Given this list of marker genes ANO5, UNC45B, SNUPN, ACTN2, KY, DES, FXR1, TNNT1, LMOD2, LAMA2, CFL2, TTN, SQSTM1, RYR1, ADSS1, NOTCH2NLC, here is a description of the gene set: studied in species Homo sapiens Any structural anomaly of the sarcomere, which is unit of a myofibril in a muscle cell, composed of an array of overlapping thick and thin filaments between two adjacent Z disks. Abnormal sarcomere morphology Human Gene Set: HP_ABNORMAL_SARCOMERE_MORPHOLOGY